The following is a description of a gene set: Severe platyspondyly Human Gene Set: HP_SEVERE_PLATYSPONDYLY species: Homo sapiens, and this is the list of marker genes: PHLDB1, EXTL3, PAM16, INPPL1, COL2A1, FGFR3, PCYT1A, LRP5